Given this list of marker genes RAD54L, PABPC4, LSM2 (LSM2 homolog, U6 small nuclear RNA and mRNA degradation associated), PPT1, LYPLA1, RFC4, GOT2, RRM1, IFRD1, NAE1, MCFD2, CDK11A, RUVBL2, SEC63, HDAC2, SLBP, MMS19, HSPE1, ILF2, HMMR, VDAC3, MSH2, ESD, ZNF131 (NCBI Gene Id 7690), HNRNPAB, GPN1, PDHB, DKC1, CYCS, ESPL1, PTGES3, HNRNPU, YARS1, TREX2, PMEL, KXD1, TYMS, GARS1, SDHA, HAT1, PPP1CC, ACTL6A, AKR7A2, VDAC2, MTX2, DDX19B, SNRNP200, KIF14, TGDS (NCBI Gene Id 23483), TOP2A, ICE1, HADH, PSMB2, ABCF1, HDDC2, MLEC, SSBP1, SPAG5, SSB, MARS1 (NCBI Gene Id 4141), XPO7, SERP1, MTREX, ZWINT, DNMT1, DNAJC11, METAP1, MTCP1, BUB1B, ATP5MC3, ATXN10, LRPPRC, NSD2, TCEA1 (NCBI Gene Id 7865), DDX39A, DUT, SSRP1, POM121, H2AZ1, EI24, USP1, ALG3, NUDC, EIF3I, RAD23A, DNAJC9, XPOT, AFG3L2, TRRAP, MCM3, CCT4, R3HDM1, GTF2A2, EIF2S2, TARS1, ZPR1, ATP5PF, NDC80, BUB1, SNRPA, BUB3, KHDRBS1, NONO, DDX18, SRRM1, MCM2, TOMM70, RPA1, HNRNPR, KHSRP, STK24, SRPK1, CEBPZ, NASP, DEK, ATP5PO, PPM1G, MCM6, CCT5, BAZ1B, SRSF1, VDAC1, FH, SAFB, DGUOK, IMMT, CAD, RFC3, HNRNPA2B1, CHAF1A, CS, TFDP1, TNPO3, TRIP13, SET, XPO1, MRPS18B, MRPS27, SHMT2, PRPS2, DOCK3, UNG (NCBI Gene Id 7374), CCNA2, UBE2S, NUP188, HCCS, IARS1, NDUFB3, PRKDC, NCBP2, EPRS1, here is a description of the gene set: Neighborhood of RFC4 replication factor C (activator 1) 4, 37kDa in the MORF expression compendium Human Gene Set: MORF_RFC4 Neighborhood of RFC4 studied in species Homo sapiens